The following is a description of a gene set: species: Homo sapiens Genes up-regulated in day 7 germinal center B cells versus day 40 germinal center B cells. To obtain insight into the genetic basis of the increase of functional activity of memory B cells over time, we compared the gene expression profiles of day 7 and day 40 NP-specific/IgG1 memory B cells, GC B cells and plasma cells in immunized WT mice and naïve B cells, before and after activation in vitro. Human Gene Set: GSE11961_GERMINAL_CENTER_BCELL_DAY7_VS_GERMINAL_CENTER_BCELL_DAY40_UP from publication Kaji T, Ishige A, Hikida M, Taka J, Hijikata A, Kubo M, Nagashima T, Takahashi Y, Kurosaki T, Okada M, Ohara O, Rajewsky K, Takemori T (PMID 23027924), and this is the list of marker genes: TJP2, MIR22HG, PDCD6, IGF2R, FRRS1, PTER, KIAA0513, IFT57, YBX3, ZDHHC11, TNFRSF11A, TUBB6, NHLRC1, POGK, DDHD2 (NCBI Gene Id 23259), YKT6, SARDH, BORA, SLC1A6, FXYD5, ZDBF2, SLURP1, ITPA, SEMA6D, PSMD1, MCTP2, PADI4, MS4A15, VOPP1, TSPOAP1, ST3GAL4, CA2, STOM, HIRIP3 (HIRA interacting protein 3), ORC6, EGLN3, SLC44A3 (NCBI Gene Id 126969), SNRPD1, CPTP, HS3ST4, LPP-AS2 (LPP antisense RNA 2), TNFAIP3, IFNGR1, GALNT2, ILF2, LGALS1, MDM2, LIN28B, CARD19, DSCC1, GARIN1B, NUDT12, TES, ATP1B1, ANAPC11 (NCBI Gene Id 51529), ALG5, CLSTN1, NEFH, GDAP1L1, NAV1, HASPIN, MLKL, MAFF (MAF bZIP transcription factor F), TXN, ARHGAP9, CTTNBP2, HACD1 (3-hydroxyacyl-CoA dehydratase 1), CRHBP, ERCC6L, MIR1915HG, JUND, PTPN12, SREK1, RNF125, INCENP, PAQR3, MAPK6, UXS1, LRP8, ADGRL4, RAD54B, AAK1, RBL2, CHAF1B (NCBI Gene Id 8208), SKP2 (S-phase kinase associated protein 2), NDFIP2, GPC1, C1orf21, IFITM5, WDHD1, SERPINB9, ABI2, NDC80, ITPRIPL2, TXNDC8, SEPTIN2, CKAP5, PTH1R, FNDC1, PDCL3, YBX1, PSMA7, ITGAL, MXD1, SLC35A4, COL4A5, MLEC, MLANA, METRN, RPUSD1, MAEL, SGO1, CAPN8, RNF152, VDAC1, ZGRF1, AVEN, RAP2A, CDCA2, RXRA, SLC7A11, PIM1, PGLYRP2, DAB1, SPN, PSMD9 (NCBI Gene Id 5715), CDK6, PRIM1, DUT, RRBP1, FBXW8, PSMD12, GYG1, SLC22A1, ARL5A, TNFRSF1A, NFKBIZ, NUP93, MCM6, KLRC3, PLPP2, SEMA4C, NCAM2, MYB (MYB proto-oncogene, transcription factor), LRP12, CLPB, SLC7A8, TACC3, KCNK10, SLC2A6, TAGLN2, ATP11B, RAB32, OLFM1, GPC5, LUZP1, TESC, ERRFI1, STK32C, GPR155, FXN, EIF2S1, OSM, ESD, DAP, PGK2, CXCL17, LONRF3, CKLF, S100A6, PBK, CDC25C, KCNAB2, CISH, CTNNA3, CERS6, KDM4D, AGTPBP1, LEPROTL1, GPR65 (NCBI Gene Id 8477), MXD3, TLCD1, PDZK1IP1, B3GNT7, PRR22, TNFAIP8L1, DUSP22 (NCBI Gene Id 56940), AMOTL1, CRACDL (CRACD like), PCNA, TMEM9B, LAG3, ALDOB, TUBG1, GLIS3 (NCBI Gene Id 648268), TPRG1, CAD, COL4A6 (NCBI Gene Id 1288), AK3 (adenylate kinase 3)